The following is a description of a gene set: species: Homo sapiens The cleavage and rejoining of intermediates, such as Holliday junctions, formed during meiotic recombination to produce two intact molecules in which genetic material has been exchanged. Human Gene Set: GOBP_RESOLUTION_OF_MEIOTIC_RECOMBINATION_INTERMEDIATES, and this is the list of marker genes: RMI1, MEIOB, MLH1, TOP2A, CENPS, FANCM, EME1, EME2, TEX11, TOP2B, SLX4, SHOC1, ANKLE1, CENPX, MUS81, ERCC4, HFM1